The following is a description of a gene set: Human Gene Set: GOMF_NUCLEAR_RECEPTOR_BINDING Binding to a nuclear receptor protein. Nuclear receptor proteins are DNA-binding transcription factors which are regulated by binding to a ligand. species: Homo sapiens, and this is the list of marker genes: PROX1, ACTN4, TRIP4, NR0B1, ZBTB7A, ASAH1 (NCBI Gene Id 79795), LCOR, SLC30A9, RARG, NCOA1, TRIP6, CCDC62, MED24, BRD8, ZNF366, PRAME, HMGA1, JUP, XBP1, MED14, CTNNB1, THRAP3, DNAAF4, MYOD1, TCF21, ASXL1, OASL, PAGR1, NR4A2, CRY1, FLT3, TAF10, LEF1, SMARCE1, TAF7, TCF7L2, FOXL2, DDX5, PKN1, NSD1, PHB2, NR1I2, PPARGC1B, TACC1, PCNA, CNOT1, ARID5A, ISL1, TRERF1, GTF2H1, MED4, NCOA7, NR4A3, PADI2, STAT3, KDM3A, TACC2, KDM4C, ETS2 (ETS proto-oncogene 2, transcription factor), MED13 (mediator complex subunit 13), NR0B2, PRMT2, CRY2, HIF1A, KDM5D, STAT5B, DCAF13, MED16, HMGN3, JUND, SMARCD3 (SWI/SNF related, matrix associated, actin dependent regulator of chromatin, subfamily d, member 3), RXRA, MED25, WBP2, NCOA3, NRIP1, RARB, CRX, NCOR2, SMARCA4, CALR, TAF1, BUD31, GTF2B, PRKCB, ESR1, TOB2, PPARG, JMJD1C, PARK7, TGFB1I1, NR1H4, LATS1, RERG, NCOA6 (NCBI Gene Id 23054), FKBP4, BAZ2A (bromodomain adjacent to zinc finger domain 2A), EP300, DDX54, MED17, WIPI1, NR4A1, YWHAH, MED12, TRIM68, KDM1A, TRIM24, TAF11, TRIP12, PPID, PARP1, VDR, C1D, SIRT1, SMAD3, PPARGC1A (PPARG coactivator 1 alpha), RNF6 (ring finger protein 6), SRARP, DCAF1, MED30, NKX3-1, DAXX, SNW1, RNF14, NR1H2, BCAS3, MMS19, MED1, STRN, NCOA2, ZNHIT3, NCOR1, LRIF1, TMF1, TADA3, CEBPB, FOXH1, ARID1A, FOXP1